Given this list of marker genes MICAL2, PDE11A, MFF, C2orf69, CLIC6, ULBP1, CPN2, COL3A1, ZBBX, BACH1, SEL1L (SEL1L adaptor subunit of SYVN1 ubiquitin ligase), CLEC12B, ZNHIT6, PBRM1, DYNAP, ITGAV, UHRF1, MDGA2, COL1A2, PRC1, HTATIP2, NAV1, IGLL1, PLEKHF2, ZNF510, CRPPA, DZIP1, WNK3, RTN1, ARSB (NCBI Gene Id 411), CAGE1, TTC19, PPM1B, MRPS30, CTPS2, KMT2A, SOD2, RNF111, RHOU, RARS1 (NCBI Gene Id 84715), MYO1D, GPC6, C16orf82, NOP14, ST8SIA3, LINC02901, CEP57, here is a description of the gene set: Human Gene Set: MIR380_5P species: Homo sapiens Genes predicted to be targets of miRBase v22 microRNA hsa-miR-380-5p in miRDB v6.0 with MirTarget v4 prediction scores > 80 (high confidence targets). from publication Chen Y, Wang X (PMID 31504780)